The following is a description of a gene set: species: Mus musculus The regulated release of mucus by the mucosa. Mucus is a viscous slimy secretion consisting of mucins and various inorganic salts dissolved in water, with suspended epithelial cells and leukocytes. The mucosa, or mucous membrane, is the membrane covered with epithelium that lines the tubular organs of the body. Mucins are carbohydrate-rich glycoproteins that have a lubricating and protective function. Mouse Gene Set: GOBP_MUCUS_SECRETION, and this is the list of marker genes: Agr2, Alox12b, Htr4, Prkce, Ano1, Ada, Atg7, Egfr, Scnn1b, Nlrp6, Traf3ip2, Sytl2, Enpp1, P2ry2, Adora3, Cyba, Vamp8, Ptger4, Atg5, Adora1, Map1lc3b, Muc2, Fosl2